The following is a description of a gene set: Binds to and modulates the activity of a cysteine-type endopeptidase involved in the apoptotic process. Human Gene Set: GOMF_CYSTEINE_TYPE_ENDOPEPTIDASE_REGULATOR_ACTIVITY_INVOLVED_IN_APOPTOTIC_PROCESS studied in species Homo sapiens, and this is the list of marker genes: BIRC8, TNFAIP8, NOL3, GAS6, TNFSF14, PRDX5, BIRC7, CTSH, RACK1, BAD, ATP2A3, BID, CASP8AP2, VIL1, XIAP, CASP1, SERPINB9, BIRC2, APAF1, BEX3, NAIP, CD27, BCL2L13, BIRC5, NOD1, NLRP1, PRDX3 (NCBI Gene Id 29017), FOXL2, NGF, BIRC3, NKX3-1